Given this list of marker genes Met, Fos, Paxbp1, Hgf, Mstn, Mir682, Gpx1, Klhl41, Neu1, Megf10, Six1, Fgf7, Gata6, Fgr, Tbx18, Ctnnb1, Atoh8, Myod1, Pax3, Sox15, Abl1, Mir351, Ankrd2 (NCBI Gene Id 56642), Atf2, Igf1, Pax7, Fgfbp1, Meis2, Zfp609, Fes, Malat1, Csf1r, Kcna5, Mir664, Ppard, Snhg15, Src, here is a description of the gene set: species: Mus musculus The multiplication or reproduction of myoblasts, resulting in the expansion of a myoblast cell population. A myoblast is a mononucleate cell type that, by fusion with other myoblasts, gives rise to the myotubes that eventually develop into skeletal muscle fibers. Mouse Gene Set: GOBP_MYOBLAST_PROLIFERATION